The following is a description of a gene set: Human Gene Set: GOMF_VASCULAR_ENDOTHELIAL_GROWTH_FACTOR_RECEPTOR_2_BINDING studied in species Homo sapiens Binding to a vascular endothelial growth factor receptor 2., and this is the list of marker genes: VEGFA, CADM4, GREM1, ITGA5, CCDC88A, CDH5, ITGB3, PDCL3, DAB2IP